Given this list of marker genes Nes, Cnih4, Ccl4, Ccl3, Jak1, Ccl5, Stat3, Stat1, here is a description of the gene set: Mouse Gene Set: GOMF_CCR5_CHEMOKINE_RECEPTOR_BINDING Binding to a CCR5 chemokine receptor. species: Mus musculus